The following is a description of a gene set: Genes down-regulated in B lymphocytes: memory versus plasmablasts. species: Homo sapiens Human Gene Set: GSE42724_MEMORY_BCELL_VS_PLASMABLAST_DN from publication Covens K, Verbinnen B, Geukens N, Meyts I, Schuit F, Van Lommel L, Jacquemin M, Bossuyt X (PMID 23613519) The recent discovery of the human B1 cells, identified by the expression of CD20, CD27 and CD43 in absence of expression of CD70 and CD69 has been subject of debate. Some studies have raised the possibility that these cells are B cells differentiating towards the plasmablast and plasma cell stage rather than being the human counterpart of murine B1 cells. No further in depth studies have been performed. Therefore, a functional comparison was made between, the proposed B1 cells and plasmablasts. We observed that for several functional characteristics (distribution of isotypes of spontaneously producted antibodies, production of antigen-specific antibodies after vaccination with both T-cell dependent as well as T-cell independent antigen, the proposed B1 cells behaved similar to plasmablasts. In addition, we were able to differentiate the proposed B1 cells in vitro, indicating that they are not from a distinct lineage as the murine B1 cells. Gene expression analysis revealed that these cells cluster between memory B cells and plasmablasts, contradicting them being the genuine human counterpart of murine B1 cells, rather revealing a preplasmablast phenotype., and this is the list of marker genes: ALDH9A1, SNX8, ASB5, PLEKHB2, PDLIM5, RBM39, VPS28, TPP1, TXNDC16, FOXO3, PURA, SRSF10, SIPA1, PLEKHG3, LRRC20, PAICS, ALDOC, TCEAL1, PCCB, RGS2 (regulator of G protein signaling 2), EMP3, CDC42EP3, STING1, PRTN3, PGAP1, CIRBP, COMT, GCNT1, ANTXR2, UBR2, PPP1CC, RPL37A, UBR1, FAM117B, DPAGT1, LIN7C, SIGIRR, RAPSN, PHKA1, GALNT12, OTULIN, GASK1B, OSBPL11, CRYZ, GBA2, TMEM241, LYL1, SQLE, IDH3G, ETFB, C1orf74, HERPUD1, GLG1, REEP3, AKT2, LSM4, PSD3, ULK2, SREBF2, GLOD4, MINDY1, SLC45A4, GNG10, MAP3K12, EID1, ARMC10, C1orf21, BHLHE40, MBNL1, RPS6KA3, MARVELD1, PHKA2, RRP1, ARPC1B, CORO1C, RMND5B, DDX46, MBD3, DHDH, DEPTOR, CITED2, PROS1, NXF1, RIF1, SELENON, RDX, P2RX7, ASAH2, MRPL24, SPECC1, PHTF1, SMC3, EML3, AGFG2, ZBTB25, PDCD4 (NCBI Gene Id 27250), KAT14, FBXW4, PRPS2, SELENBP1, PHKB, ELP1, NF1, MEF2C, CMTM6, PLSCR4, SVIL, PRKAR1A, HFE, PHF20, CLTC, EHBP1 (EH domain binding protein 1), TRAK2, LMO2, FYN, ENTREP3, HPRT1, B3GNT8, CASP6, TM9SF2, PRRG1, ACAT1, GANAB, KRTAP4-11, CIPC, KIFAP3, TOGARAM1, CENPA, CCDC82, DSTYK, LRP6, PDHA1, NBDY, ZCCHC24, ANAPC11, TBC1D4, MFSD3, MFSD6, C5orf34, TACC1, MOB3A, LPIN1, POLR2J, TTC28, WDR26, NOSTRIN, DPP7, RSRC1, NONO, KIF13A, PLD2, SRSF5, TFDP2, RNASEH2C (ribonuclease H2 subunit C), MTMR11, SOX21, KCNQ1OT1, ZFP90, HLTF, OXCT1, PRKRA, RPS7, RNF5, TBXAS1, BDH1, CNRIP1, CYP4V2, MTA3, ZMYM1, STX16, SFT2D2, STK10, RUFY1, ANKH, ATP6V0A1, TUFT1, ZNF362, NCOA1, ADSS2, ARHGEF7, LGALS1 (galectin 1), TSNAX, PAQR4, RPS4X, TMTC4, SEPTIN9, GLO1, GALC, SCAP, SCARB1, PGGT1B, RPL31, PAPSS1, RAMP1, TKT, TMCO6, SMIM13, EIF4G3, SCARNA13, CDC14B